Given this list of marker genes ARHGEF10L, ATXN7L3B, GRP, PLEKHG2, FRS3, CLK2, ARID1A, KPNB1, ID1, DAGLB, KCP, DHRSX, NELFA (NCBI Gene Id 7469), PSD, MATCAP1, ELAVL1, CPN1, DDX54, CDYL2, ARHGAP28, ABHD8, RABAC1, MKI67, TGFB2 (NCBI Gene Id 7042), GNAO1, EZH2, FHIT (NCBI Gene Id 2385), KYNU, SVOP, PLEKHA7, LLPH, NOL9, HMGN1, QTRT1, LIN54, GTF2E1, TCEA3 (transcription elongation factor A3), VPS18, THBS4, CCAR1, here is a description of the gene set: The molecular mechanism responsible for a decline of stem cell functioning after replicative stress remains unknown. We used mouse embryonic fibroblasts (MEFs) and hematopoietic stem cells (HSCs) to identify genes involved in the process of cellular aging. In proliferating and senescent MEFs one of the most differentially expressed transcripts was Enhancer of zeste homolog 2 (Ezh2), a Polycomb group protein (PcG) involved in histone methylation and deacetylation. Retroviral overexpression of Ezh2 in MEFs resulted in bypassing of the senescence program. More importantly, whereas normal HSCs were rapidly exhausted after serial transplantations, overexpression of Ezh2 completely conserved long-term repopulating potential. Animals that were reconstituted with 3 times serially transplanted control bone marrow cells all died due to hematopoietic failure. In contrast, similarly transplanted Ezh2-overexpressing stem cells restored stem cell quality to normal levels. In a genetic genomics screen, we identified novel putative Ezh2 target or partner stem cell genes that are associated with chromatin modification. Our data suggest that stabilization of the chromatin structure preserves HSC potential after replicative stress. Genes down-regulated on serial passage of MEF cells (embryonic fibroblast). species: Mus musculus from publication Kamminga LM, Bystrykh LV, de Boer A, Houwer S, Douma J, Weersing E, Dontje B, de Haan G (PMID 16293602) Human Gene Set: KAMMINGA_SENESCENCE